Given this list of marker genes TK1, DTYMK, TK2, DPYD, DHFR2, here is a description of the gene set: species: Homo sapiens The chemical reactions and pathways involving any one of a family of organic molecules consisting of a pyrimidine base covalently bonded to a sugar deoxyribose (a deoxyribonucleoside). Human Gene Set: GOBP_PYRIMIDINE_DEOXYRIBONUCLEOSIDE_METABOLIC_PROCESS